The following is a description of a gene set: Human Gene Set: WP_SREBF_AND_MIR33_IN_CHOLESTEROL_AND_LIPID_HOMEOSTASIS SREBF and miR33 in cholesterol and lipid homeostasis studied in species Homo sapiens, and this is the list of marker genes: PPARGC1A, SREBF2, SIRT1, SCD, SREBF1, MED15, PRKAA1, MIR33A, MTOR, NR1H3, HMGCS1, FASN, PPARA, MIR33B, SIRT6, ABCA1, HMGCR, LDLR